The following is a description of a gene set: Reactome Pathway: IP3 and IP4 transport between cytosol and nucleus species: Homo sapiens part of: Inositol phosphate metabolism Inositol trisphosphate (IP3) and tetrakisphosphate (IP4) molecules are exported from the cytosol to the nucleus. It is unknown whether this occurs by diffusion or is mediated by a transporter., and this is the list of marker genes: NUP214, NUP205, AAAS, NUP35, POM121C, POM121, SEC13, NUP153 (nucleoporin 153), RANBP2, NUP62, NUP43, NUP160, NUP188, NUP58, NUP54, NUP88, SEH1L, NUP37, NUP133, NUP210, NUP50, NUP85, NUP155, NUP42, TPR, NDC1, RAE1, NUP98, NUP93, NUP107